The following is a description of a gene set: studied in species Homo sapiens from publication Hay SB, Ferchen K, Chetal K, Grimes HL, Salomonis N (PMID 30243574) Human Gene Set: HAY_BONE_MARROW_CD34_POS_MEP, and this is the list of marker genes: SVOPL, DEPTOR, HACD1, HYAL3, SPINK4, CPB1, ABCC4, FREM1